Given this list of marker genes GRIA3, SFPQ, NUDT12, PDZRN3, NUDT4, STK24, APP, PRR12, DACT1, LIN54, C7orf57, NR5A2, DGKH, FBXO45, KPNA3, BRF2, ELOVL2, SCARF1, C1QTNF7, JAK2, KDM6A, CTU2, ARID4B, SCX, PNISR, TOB1, DLX2, RDX, TAOK1, BCL6, NAA25 (N-alpha-acetyltransferase 25, NatB auxiliary subunit), CEP76, UBE2B, MEX3B, UBN2 (NCBI Gene Id 254048), PPP3CA, IFT70A, SEPHS1, HIPK3, LEMD3, RNF149, IGFBP1, ADAM28, VEZF1, ZNF569, SRSF2, FBLN5, N4BP2, LILRA1, CLOCK, PAXBP1, SLC6A17, AUTS2, MLLT6, MMS22L, TLE4, RNF216, RIPPLY2, GTF2A1, TM4SF4, DLL1 (delta like canonical Notch ligand 1), PTPRE, SNAPC1, BAG2, SPRY2, EIF4ENIF1, FOXO1, EEA1, UBE2Q2, EIF4G3, DNALI1, USP34, RASEF, SLC39A10, COL1A2, CEP41, MALT1, DACH1, NPY, MARK1, ANO4, BTAF1, ITM2C, SOS2, CTTNBP2NL, ID1, DAAM1, NASP, RNF180, SNCAIP, PEAK1, CASP8AP2, ABI1, PUM1, RPS16, PUM2, ASAP2, RPRD1A, ZNF236, RAB11B, CD38, PSD3, DR1, MON2, DMTF1, ZMYM4, CMPK1, WWC2, TBC1D2B, BTNL9, FOXN2, UTRN, ACVR2B, PDLIM5, FBXL3, NUP58, GUCY1B1, C18orf63, PHC3, PIKFYVE, DSG2, FRS2, KIF21A, EBF3, CAMTA1, CTNNB1, IGF1R, MECOM, ICE1, ZNF302, BMPR2, HS6ST2, E2F8 (NCBI Gene Id 79733, E2F transcription factor 8), SPOCK3, ADRB2, TMEM132B, POLR1F, DERL1, UBE2H, LATS1, GTF2I, CAB39, ETS2, PAN3, PLAG1, TBR1, NCKAP1, HTR2A, RC3H1, FAM3C, ATRX, FNDC3A, CLDN1, SPOPL, STON2, NGDN, DCAF7, LY75, ZNF518B, ZNF367 (zinc finger protein 367), KLF12, PI15, C5orf58, PDE10A, THAP12, F3, PRPF8, CNNM4, PPM1D, CREBZF, MYT1L, ULK1 (unc-51 like autophagy activating kinase 1), EFR3A, MARCHF6, ZNF780A, FAM204A, FNBP4, FREM2, KLF2, SOWAHC, LCOR, SRSF1, HOXA9, ZFY, HNRNPA1, BAZ1B, DCC, BMAL1, AP1S3, LRRC32, NUFIP2, HECTD2, DKK3, LIN9, VAPA, TVP23C, AMMECR1, RAD21, ZNF506, GLCCI1, MBNL1, U2SURP, VMA21, RPRD1B, DCBLD2, IREB2, DYNC2LI1, PECR, ELOVL7, NCOA2, REV3L, OLFML2B, SOX9, SP8, GIGYF2, ASAH1, TGFBR3, BCAP29, B3GLCT, RIMKLB, RAB11FIP3, LRP1B, ARID1B, FBXO43, BASP1, DENND4A, SPTB, ASB11, CLASP2, HIC1, HYCC1, SPAST, FSTL5, CYP7B1, SCN2A, SMARCA5, NR4A3, SLC4A5, USP24, FOXP1, DOCK1, SMARCA2, SPEN, GDAP1, NUP98, PSIP1, SH3GL3, FBN1, GNAQ, ACVR1 (NCBI Gene Id 90), GULP1, GDAP2, COL19A1, SLC6A11, L3HYPDH, AKAP12, PALS2, KLHL2, PTMS, ITM2B, IRX3, PRRC1, ARFGEF2, IKZF2 (NCBI Gene Id 51173), CLDN16, LRCH4, HSPA14, ANO5, LAMP2, PRDM2 (PR/SET domain 2), ZFYVE21, PPP4R3B, SEPTIN9, RABGGTB, F2RL1, SELENOK, CNOT6L, SDHAF3, TAFA4, LRRC1, PRKAA1, GOLIM4, SET, KIF3A, FNDC3B, LRRTM4, CALN1, UNC119B, NOL4, C11orf54, TAS2R14, EMP2, ZNF800, DCLRE1B, KLF3, KCNJ15, BRIP1, PRDM16, USP25, PCSK2, MTARC1, TLE1, EPHB4, KIAA0408, USP12, NRBF2, PPP1R2, PANK3, CECR2, MPC2, GNAI3, SRBD1, DNAJB5, ZNF326, GTF3C3, TTF2, TAF4B, YTHDC1, TRPM7, RHOBTB3, RAB10, GNAL, NBEA, RNF24, XPO1, TVP23B, PEX5L, BTF3L4, GATA3, TGFB3, ZBTB39, CIAO2A, STK40 (NCBI Gene Id 83931), ANKRD44, FZD6, NDC1, UBQLN1, CARF, UBN1, JAG1, NEUROG2, ZMIZ1, SLC39A6, SLC2A13, HNRNPD, CCNA2, EPS15L1, MEF2C, ZIC1, GRM5, LYSMD3, LRP6, PLCL2, OLIG3, FSCN1, NECTIN1, PHACTR2, CTR9, FRMD4B, CADM1, TCERG1L, AKAP10 (A-kinase anchoring protein 10), WDR26, TMED7, CCL7, OTX2 (NCBI Gene Id 5015), ID4, CPEB3, FGF7, ELK4, ZNF827, USP32, WIPI1, BST1, DENND2B, ACTR3, CPEB2, BRD1, TRGC1, OXR1, CILK1, CNOT6, CRISPLD1, PTCH1, TRAK1, FBXO33, NRP1, UBR1, MATN2, AGTR1, CLDN12, NRP2, RHOA, PIAS1, FRMD6, PTER, TMEM87A, ANAPC13, EDIL3, LTN1, UBXN7, TSLP, ZC3H11A, RAB11FIP2, NF1, ERI1, TCF20, FYTTD1, GPR158, GLS, PPP4R2 (protein phosphatase 4 regulatory subunit 2), GPR37, AHR, CHD3, MYCN, PIK3C2A (phosphatidylinositol-4-phosphate 3-kinase catalytic subunit type 2 alpha), MAN1A1, MED6, AAK1, POU2AF3, SBF2, SLC35A3, RORA, TMTC2, BMPER, TUT4, HERC2, PLEKHA6, AKAP9, SV2B, ZNF430, GOLGA2, ATAD5, HEATR5B, CDC7, HMGXB4, RIF1, B3GNT2 (NCBI Gene Id 55878), SUN1, ACTL6A, BLTP1, CCNE2, PHYHIPL, OTUD6B (NCBI Gene Id 51633), ZMYND8, HES1, SORBS1, TET2, AKAP13, E2F5, VAV3, RAB2A, CERT1, ARAP2, NAA16, RICTOR, HIVEP2, ZDHHC20, DCLK3, COL4A1, NUDT11, SALL3, ZMYM6, NFAT5, AKTIP, CDH20, BDNF, SEC22C, HMGCR, CEMIP2, LIX1L, DOCK11, POU4F2, ARHGEF33, CENPE, LIPG, MMP20, MMAB, NR2F2, FSHB, BTBD3 (BTB domain containing 3), TRIM63, SYNGR3, ATG2B, KBTBD7, SRSF11, CACNA2D1, FLT3LG, SLC18A2, YY1, CUL1, NPY1R (NCBI Gene Id 4886), FA2H, DOP1A, ROCK1, CCDC186, ARHGAP44, LGALSL, SP4, HOOK3, MLLT10, GP1BA, SCAI, KRAS, ACTR3C, DLL4, OTUD4, KRBOX4, MAST4, ISM1, ERF, KIF2A, APPL1, ALKBH8, ALDH1L2, SLC34A2, WNT5B, TEAD1, CRACD, STK38L, TMTC4, TAF2, CFTR, PPP1R15B, OPA1, MRPL44, LHFPL3, WAC, JAG2, SYF2, C11orf58, ULBP1, TCF3, ITCH, CCDC126, GNB4, GRK5, LSM14A, PPM1L, ELAVL2, WASF3, NUP35, MEF2D, HECTD1, TRA2A, CDK19, UBE2W, RAB3GAP2, ARIH1 (NCBI Gene Id 25820), ARHGEF28, BHLHE40, AFF3, APOOL, SLC6A14, RALGDS, HIP1, SPESP1, KIF11, ARHGAP20, KDM2B, YTHDF3, EIF1AD, DNPEP, ZBTB14, UBTF, EFNB1, MAPKAPK5, RTN1, NLGN1, NADK2, CACNA1C (calcium voltage-gated channel subunit alpha1 C), SAMD12, PLPP3, IMPACT, FGFR2, KLHDC2, C1QBP, POLR2K, FAT3, SHOC2, RAB6D, DOCK10, KDM7A, KIN, ATL1, TNS3 (tensin 3), THRB, EGFL6, VCL, CORO1C, BLOC1S4, ATP6V1H, BRWD3, ACBD3, MBLAC2 (NCBI Gene Id 153364), NKTR, COG7, PRPF38B, PHIP, PAK2, COL11A1, DUSP6, CCDC102B, SGTB, JPH1, PSD2, MAP2 (microtubule associated protein 2), ANK3, UBL3, RSRP1, FAM117B, RBPJ, PPP1R3F, CNTN1, MIF4GD, PFKFB3, PTBP3, MSANTD2, MINDY3, ITGA6, GPRIN3, MYCBP2, CEPT1, MED14, DCUN1D4, SDC2, CCNY (cyclin Y), SEMA3C, FBXO34, TRIM6, SLC6A4, HYCC2, TSHZ3, PPP4R3A, RAB6B, USF3, EIF4A2, INO80D, TIGD7, TFRC, HNRNPA2B1, SLAIN2, FAM76B, DPM1, SCAMP1, PCDH8, RBM22, RNF138, IPMK, SGO1, UBE3C, GRHL3, GNA13, ZNF292, TET3, KDM5B, CRY1, GRM3, SATB1, LYPLAL1, SPINDOC, ARID4A, PPP1R21, DCAF6, AASDH, CWC22 (CWC22 spliceosome associated protein homolog), GSK3B, TASP1, MTF1, UBFD1, RAPH1, WWC1, CLIP1, ATF2, GABRG1, RSF1, NFYB, AKAP6, PPFIA2, FGD6, HNRNPA1L2, PARD6B, NR3C1, FUT9, CHD1 (chromodomain helicase DNA binding protein 1), RBM12B, RFX1, SPRY1, LGR4 (NCBI Gene Id 55366), CPNE2, NAA20, ITGAV, TRHDE, IER5, PPM1A, BMP3, CEP192, RELCH (RAB11 binding and LisH domain, coiled-coil and HEAT repeat containing), DDX21 (DExD-box helicase 21), PARPBP, MBNL2, RAB14, MNX1, CREBRF, ZFPM2, MAGI1, RHOT1, SCN7A, SECISBP2L, KMT2C, PIK3R4, ZFYVE16, LRRC4, QKI, KIAA1217, DENND1B, SPRED1, KLF4, ARHGAP12, CEP57, MAP2K3 (NCBI Gene Id 92079), here is a description of the gene set: studied in species Homo sapiens from publication Chen Y, Wang X (PMID 31504780) Genes predicted to be targets of miRBase v22 microRNA hsa-let-7b-3p in miRDB v6.0 with MirTarget v4 prediction scores > 80 (high confidence targets). Human Gene Set: LET_7B_3P